The following is a description of a gene set: Human Gene Set: GOCC_MITOTIC_COHESIN_COMPLEX A cohesin complex that mediates sister chromatid cohesion during mitosis; has a subunit composition distinct from that of the meiotic cohesin complex. species: Homo sapiens, and this is the list of marker genes: DDX11, SMC1A, STAG2, SMC3 (structural maintenance of chromosomes 3), STAG1, RAD21, SGO2